The following is a description of a gene set: from publication Noushmehr H, Weisenberger DJ, Diefes K, Phillips HS, Pujara K, Berman BP, Pan F, Pelloski CE, Sulman EP, Bhat KP, Verhaak RG, Hoadley KA, Hayes DN, Perou CM, Schmidt HK, Ding L, Wilson RK, Van Den Berg D, Shen H, Bengtsson H, Neuvial P, Cope LM, Buckley J, Herman JG, Baylin SB, Laird PW, Aldape K, Cancer Genome Atlas Research Network (PMID 20399149) studied in species Homo sapiens Human Gene Set: NOUSHMEHR_GBM_SILENCED_BY_METHYLATION Top 50 most differentially hypermethylated and down-regulated genes in proneural G-CIMP (a CpG island methylator phenotype) GBM (glyoblastoma multiforme) tumors. We have profiled promoter DNA methylation alterations in 272 glioblastoma tumors in the context of The Cancer Genome Atlas (TCGA). We found that a distinct subset of samples displays concerted hypermethylation at a large number of loci, indicating the existence of a glioma-CpG island methylator phenotype (G-CIMP). We validated G-CIMP in a set of non-TCGA glioblastomas and low-grade gliomas. G-CIMP tumors belong to the proneural subgroup, are more prevalent among lower-grade gliomas, display distinct copy-number alterations, and are tightly associated with IDH1 somatic mutations. Patients with G-CIMP tumors are younger at the time of diagnosis and experience significantly improved outcome. These findings identify G-CIMP as a distinct subset of human gliomas on molecular and clinical grounds., and this is the list of marker genes: SPON2, SLC39A12, CRYGD, EPHX2 (NCBI Gene Id 2053), CCNA1, FLNC, ITGBL1, B3GNT5, CA3, G0S2, PAMR1, LGALS3, FAM221A, TTC12, JHY, LDHA, CHST6, PDPN, SLC35G2, OCIAD2, F3, SEL1L3, RAB36, RARRES2, ACSS3, NMNAT3, ARMC3, TRIP4 (thyroid hormone receptor interactor 4), CHRDL2, TOM1L1, FKBP5, MTARC2, CNMD, DYNLT5, GJB2, FMOD, LGALS8, FZD6, FABP5, RBP1, RARRES1, BIRC3, CTHRC1, SLC25A20, MMP9, CBR1, CHI3L1, AQP5, CABCOCO1, SEMA3E